The following is a description of a gene set: part of: Cytochrome P450 - arranged by substrate type Approximately a quarter of the 57 human CYPs still remain "orphans" in the sense that their function, expression sites, and regulation are largely not elucidated. While there is enough experimental evidence to know that all these proteins get made and can catalyze CYP-like reactions in vitro, evidence of in vivo function and substrate specificity is insufficient to allow them to be placed in any of the classes in the functional scheme. studied in species Homo sapiens Reactome Pathway: Miscellaneous substrates, and this is the list of marker genes: CYP4F22 (cytochrome P450 family 4 subfamily F member 22), CYP2S1, CYP4F2, CYP2D6, CYP2U1, CYP4F11, CYP4A22, CYP2W1, CYP4B1, CYP3A43, CYP4F3, CYP4A11